Given this list of marker genes IL4, KMT5B, PAXIP1, IL4R, IL2, CD37, BTK, SHLD3, HMCES, PMS2, HPX, TLR9, RBP4, ATAD5, STAT6, IL2RG, HLA-E, CLCF1, TGFB1, IL10, TFRC, C17orf99, STX4, IL21, TNFSF4, IL5, GALNT2, GPI, TNFRSF4, IL6, EPHB2, XCL1, IL13, IL13RA1, MSH2, CD28, PTPRC, IL33, EXOSC3 (NCBI Gene Id 51010), MAD2L2, PHB2, TNFSF13, TBX21 (T-box transcription factor 21), KMT5C, SHLD1, TP53BP1, VAMP3, SASH3, PHB1, RIF1, MLH1, EXOSC6, MZB1, XBP1, CD40 (CD40 molecule), SHLD2, NSD2, DNAJB9, CD86, here is a description of the gene set: species: Homo sapiens Any process that activates or increases the frequency, rate, or extent of immunoglobulin production. Human Gene Set: GOBP_POSITIVE_REGULATION_OF_IMMUNOGLOBULIN_PRODUCTION